The following is a description of a gene set: Reactome Pathway: Signaling by NOTCH1 part of: Signaling by NOTCH NOTCH1 functions as both a transmembrane receptor presented on the cell surface and as a transcriptional regulator in the nucleus.<br><br>NOTCH1 receptor presented on the plasma membrane is activated by a membrane bound ligand expressed in trans on the surface of a neighboring cell. In trans, ligand binding triggers proteolytic cleavage of NOTCH1 and results in release of the NOTCH1 intracellular domain, NICD1, into the cytosol.<br><br>NICD1 translocates to the nucleus where it associates with RBPJ (also known as CSL or CBF) and mastermind-like (MAML) proteins (MAML1, MAML2 or MAML3; possibly also MAMLD1) to form NOTCH1 coactivator complex. NOTCH1 coactivator complex activates transcription of genes that possess RBPJ binding sites in their promoters. <br><br> studied in species Homo sapiens, and this is the list of marker genes: CNTN1, KAT2A, MIB2, SKP1, MAMLD1, NBEA, DTX1, NUMB, HIF1A, NCSTN, HDAC5, ITCH, HES5, TLE2, CCNC, ARRB1, CUL1, HEY2, HDAC4, NCOR1, HEY1, TBL1XR1, KAT2B, PSEN1, RBX1, ADAM10, RBPJ, MAML3 (NCBI Gene Id 55534), ADAM17, UBB, DLL4, NCOR2, HDAC10, TLE1, DTX4 (deltex E3 ubiquitin ligase 4), FBXW7, MAML2, DTX2, NEURL1B, APH1A, JAG2, HDAC2, SNW1, DNER, TBL1X, HDAC11, UBC (NCBI Gene Id 7316), PSEN2, EP300, HEYL, HDAC6, RPS27A (ribosomal protein S27a), TLE3, CDK8 (NCBI Gene Id 1024), JAG1, PSENEN, ARRB2, HDAC8, APH1B, MIB1, HES1, UBA52, CREBBP, HDAC3, HDAC7, MAML1, HDAC9, NOTCH1, NEURL1, MYC, TLE4, DLL1, DLK1, HDAC1